The following is a description of a gene set: Adenosine is released into the extracellular space from nerve terminals and cells subjected to ischemic stress. This nucleoside modulates a plethora of cellular functions via occupancy of specific receptors. Adenosine is also an important endogenous regulator of macrophage function, because it suppresses the production of a number of proinflammatory cytokines by these cells. However, the mechanisms of this anti-inflammatory effect have not been well characterized. We hypothesized that adenosine may exert some of its anti-inflammatory effects by decreasing activation of the transcription factor nuclear factor-kappaB (NF-kappaB), because gene expression of most of the proinflammatory cytokines inhibited by adenosine is dependent on NF-kappaB activation. Using bacterial lipopolysaccharide (LPS)-stimulated RAW 264.7 macrophages, we found that adenosine as well as adenosine receptor agonists decreased the production of tumor necrosis factor (TNF)-alpha, a typical NF-kappaB-regulated cytokine. This effect of adenosine was not due to an action on the process of TNF-alpha release, because adenosine suppressed also the intracellular levels of TNF-alpha. However, cDNA microarray analysis revealed that mRNA levels of neither TNF-alpha nor other cytokines were altered by adenosine in either LPS-activated or quiescent macrophages. In addition, although LPS induced expression of a number of other, noncytokine genes, including the adenosine A2b receptor, adenosine did not affect the expression of these genes. Furthermore, adenosine as well as adenosine receptor agonists failed to decrease LPS-induced NF-kappaB DNA binding, NF-kappaB promoter activity, p65 nuclear translocation, and inhibitory kappaB degradation. Together, our results suggest that the anti-inflammatory effects of adenosine are independent of NF-kappaB. species: Mus musculus Mouse Gene Set: NEMETH_INFLAMMATORY_RESPONSE_LPS_DN from publication Németh ZH, Leibovich SJ, Deitch EA, Vizi ES, Szabó C, Hasko G (PMID 12766259) Genes down-regulated in RAW 264.7 cells (macrophage) 3 hr after stimulation with bacterial lipopolysaccharide (LPS)., and this is the list of marker genes: Mbp, Abcg1, Aurka (aurora kinase A), Fos, Itga4, Chek1, St8sia4, Gtf2i, Apobec1, Scd2, Acadm, Rassf5, Mxi1, Col11a2, Lmo4, Lyl1, Numb, Zfp36l1, Rgs2, Orc5, Fen1, Slc6a12, Mki67, H1f0, Slbp (NCBI Gene Id 20492), Ccnf, Apex1, Hells, Hspa4l, H2ac4, Zmat3